The following is a description of a gene set: Mouse Gene Set: GOBP_FAS_SIGNALING_PATHWAY species: Mus musculus The series of molecular signals initiated by the binding of a ligand to a Fas receptor on the surface of the cell, and ending with the regulation of a downstream cellular process, e.g. transcription. Fas is a death domain-containing member of the tumor necrosis factor receptor (TNFR) superfamily., and this is the list of marker genes: Smad5, Tmbim1, Sp100, Fas, Casp8ap2, Zdhhc7